The following is a description of a gene set: Human Gene Set: WP_HOSTPATHOGEN_INTERACTION_OF_HUMAN_CORONAVIRUSES_APOPTOSIS species: Homo sapiens Host-pathogen interaction of human coronaviruses - apoptosis, and this is the list of marker genes: FASLG, MAPK12, BCL2L1, AKT1, CASP9, MCL1, CASP8, BCL2L11, MAPK13, TNF, CASP3, ADAMTSL4-AS1, BCL2, BAX (BCL2 associated X, apoptosis regulator), APAF1, MAPK14, FADD, BID, CASP7, MAPK11, BBC3, BAD